Given this list of marker genes GHRL, PPIF, MIR3667HG, TRDMT1, CCDC142, CXorf66, PDXP, ERO1A, RORA, LDB2, SLC49A3, EPO, GCLM, here is a description of the gene set: Genes predicted to be targets of miRBase v22 microRNA hsa-miR-1281 in miRDB v6.0 with MirTarget v4 prediction scores > 80 (high confidence targets). species: Homo sapiens Human Gene Set: MIR1281 from publication Chen Y, Wang X (PMID 31504780)